Given this list of marker genes GADD45GIP1, ASPRV1, LYSMD2, ARMC6, MED25, TACR2, ATP5MG, TRMT1, PI4KA (NCBI Gene Id 5297), TK1, FASN, CEP250, PKP3, RAMP1, ARRB1 (arrestin beta 1), SELENOP, WDR43, TSPAN14, TUBA1B, CDC20, MUC13, S100A1, AKR7A2 (NCBI Gene Id 94395, aldo-keto reductase family 7 member A2), SHMT1, RBM42, ASPM, RPL31, DPP7, SYNPO, WASL, ENC1, ANAPC15 (anaphase promoting complex subunit 15), APCDD1, DUSP6, ECHDC3, SLC7A7, FOXL1, MLLT10, ASB5, PDXK, FKBP1A, LPGAT1, URI1, THRAP3, FBLN5, PDZK1IP1, IFT80, KIF1C, DBH, EPRS1, AHR, THYN1, KCNJ3, DCAF4, IRX5, AKR1B10, RND3, CTNNA1, HIGD2A, REEP6, CA14, CHDH, CD300C, RNH1, PITX3, ABCF1, NSMF, MMP12, RPS14, MEIG1, LGALSL, MYL6, CORO1A, ERCC6L, FKBP11, LCMT1, LYAR (Ly1 antibody reactive), MRPS28 (NCBI Gene Id 64947), MLH1, ZMPSTE24, RAP2A, MMP23B, FKBP1B, KLF5, NDRG4, GUSB, AAAS, GASK1B, SCGB3A1, NEPRO (NCBI Gene Id 285338), DCAF11, JARID2, ALDH18A1, CD93, STEAP1, PIGF, CENPM, MRPL21, NELL2, TRIM11, RAB1B, ATG3, MRPL52, UXT, TAF10, MED29, GP1BB, HMGCS1, DAG1, CD48, LHB, PPP4R1, GALC, HAUS8, ATP5ME, DNAJC9, RECQL4, TBX4, MRPL51, KLK6, H1-10, MRPL23, SERPINB7, TFF2, QRSL1, PADI3, HLA-DRA, TOPBP1, SPA17, LAP3, EMC8, HHEX, ANXA3, HLA-DMA, SOBP, CENPV, KXD1 (NCBI Gene Id 79036), POLR2F, GNAO1, EEPD1, CPA3, PTPN6, APOC2, MRPS24, SC5D, SSR4, SSBP2, TMEM131, RFC1, SIDT2, TKT, FRRS1, LEPR, NUDC, SUPT16H, SCNN1A, TSPAN5, RAD1, AKR1B1, FGF14, CDKN2C, EML5, DENND4B, DGLUCY, CLINT1, GPR146, LETM1, LGALS2, SETD4 (NCBI Gene Id 54093), NDUFAB1, GMPR, VOPP1, SOCS6, TRIB2, CCT6A, CD164, MARVELD2, SRSF9, EEF1B2, TIMM8A, ZRSR2 (NCBI Gene Id 8233), GALNT2, STRBP, CXCL14, HYOU1, ACTN2, LSM3, SYT9, TFEB, RGS10, XRCC6, GLCCI1, PRRC1, AQP1, ANXA1, CCDC9, CENPT, ADCY4, DDX39B, here is a description of the gene set: Genes up-regulated in comparison of dendritic cells (DC) stimulated with LPS (TLR4 agonist) at 0.5 h versus those stimulated at 24 h. from publication Amit I, Garber M, Chevrier N, Leite AP, Donner Y, Eisenhaure T, Guttman M, Grenier JK, Li W, Zuk O, Schubert LA, Birditt B, Shay T, Goren A, Zhang X, Smith Z, Deering R, McDonald RC, Cabili M, Bernstein BE, Rinn JL, Meissner A, Root DE, Hacohen N, Regev A (PMID 19729616) species: Homo sapiens mouse primary BMDCs were stimulated with tlr ligands and gene expression changes were profiled on Affymetrix arrays Human Gene Set: GSE17721_0.5H_VS_24H_LPS_BMDC_UP